The following is a description of a gene set: Human Gene Set: GOBP_POSITIVE_REGULATION_OF_EXTRACELLULAR_MATRIX_ASSEMBLY Any process that activates or increases the frequency, rate or extent of extracellular matrix assembly. studied in species Homo sapiens, and this is the list of marker genes: RGCC, TGFBR1, SMAD4, SMAD3, TGFB1, EMILIN1, SOX9, MIR27B, AGT